The following is a description of a gene set: from publication Yevshin I, Sharipov R, Kolmykov S, Kondrakhin Y, Kolpakov F (PMID 30445619) Human Gene Set: METHYLCYTOSINE_DIOXYGENASE_TET_UNIPROT_A0A023HHK9_UNREVIEWED_TARGET_GENES species: Homo sapiens, and this is the list of marker genes: SETDB1, FASTKD5, GTF3A, BMF, RBMS1, GUSB, TMEM39B, FRG1-DT, RNA5SP455, SRCAP, ADAMTS3, ATP1A1-AS1, MST1P2, DOCK10, METTL25, PPP1R12A, GSPT1, CCDC183-AS1, C1QTNF6, ABHD6, GALNTL5, B4GALT5, PRELID1P2, SECISBP2L, TMEM248, COX5A, ERLIN1, GEMIN5, TCEAL8P1, INTU, MT-ND1, POLE, KIAA0753, HAGH, MT-CYB, ATAD2, RNU6-430P, CNTFR-AS1 (NCBI Gene Id 415056), MT-TQ, TNFAIP3, SNORD43, MT-RNR1, FAHD1, HSPA12A, PUM3, CLUAP1, MUC20, DHX30, LINC01596, MT-TW, C15orf61, RN7SL98P, RPL30P16, RNA5SP145, RNPEP, FGD2, USP30, PRMT5, LINC01378, SNX16, AZIN1, RANGAP1 (NCBI Gene Id 6381), SFXN5, SPHK2, ATPAF1, NDUFV2, FRG1HP, LINC02173, INO80B-WBP1 (INO80B-WBP1 readthrough (NMD candidate)), NENFP1, SYT7, RFC3, RPRD1A, ZNF440, NBPF1, MYH11, IGHV3-76, TSPAN4, RAB4A, PSMD9, EEF1D, MARK2P21, SPRED3, DNAJB6P5, MTCO3P12, MT-TC, CROCCP2, TRAK1, FRG1CP, PTK2, MT-TA, WDR24, ATR, RAB4A-AS1, TFPI, SLC30A5, ENSG00000282936, ENSG00000261840, TXNDC17, TSNARE1, POLE3, MT-TY, BNIP1, ATAD3A, CTAGE1, NYNRIN (NYN domain and retroviral integrase containing), TRIB3, C9orf43, MIR3123, DNAJC9, SMIM15-AS1, PPP1R10, MT-TI, UBOX5, MIR4486, RNA5SP267, TEAD4, DUS2, LINC00511, TMED2, INPP1, RBL1, FRG1, TMEM116, LINC02918, RNF185, ERP29, COL5A1, NBAS, RPS14P8, MCTP2, USP17L18, NANOGNBP1, CHD3, SYN2, ZDHHC4, RPL3, IER3IP1, PXMP2, HOXB-AS3, POLR2L, PFKP, RCC1, DGKB, GPR61, PODNL1 (NCBI Gene Id 79883), MT-ND2, IQCH-AS1, LINC03110, MTCO1P17, MT-TF, PLCG1, DCAKD, CTH, ZFP69B, NPHP4, CCDC106, MT-TN, TBCD, EGFLAM, MT-TM, HOXB3, ATXN2, MND1, RNA5SP351, PLEKHJ1, MT-TL1, TIGD5, INO80B, ATP7B, UBE2Q2, CHMP6, SNHG7 (NCBI Gene Id 84973), AQP1, AGTR1, IPO13, UTRN, NIFKP4, MT-CO1, HDAC6